Given this list of marker genes Samhd1, Itpa, Nudt16, Ada, Nudt15, here is a description of the gene set: The chemical reactions and pathways resulting in the breakdown of purine nucleoside triphosphate, a compound consisting of a purine base linked to a ribose or deoxyribose sugar esterified with triphosphate on the sugar. studied in species Mus musculus Mouse Gene Set: GOBP_PURINE_NUCLEOSIDE_TRIPHOSPHATE_CATABOLIC_PROCESS